The following is a description of a gene set: from publication Joseph J, Mudduluru G, Antony S, Vashistha S, Ajitkumar P, Somasundaram K (PMID 15318170) Histone deacetylase (HDAC) inhibitors induce growth arrest and apoptosis in a variety of human cancer cells. Sodium butyrate (NaB), a short chain fatty acid, is a HDAC inhibitor and is produced in the colonic lumen as a consequence of microbial degradation of dietary fibers. In order to dissect out the mechanism of NaB-induced growth inhibition of cancer cells, we carried out expression profiling of a human lung carcinoma cell line (H460) treated with NaB using a cDNA microarray. Of the total genes analysed, there were genes with a mean expression value of 2.0-fold and higher and genes with a mean expression value 3.0-fold and lower in NaB-treated cells. For a few selected genes, we demonstrate that their expression pattern by semiquantitative reverse transcription-polymerase chain reaction (RT-PCR) analysis is matching with the results obtained by microarray analysis. Closer view at the expression profile of NaB-treated cells revealed the downregulation of a total of genes associated with cytokine signaling, in particular, interferon gamma (IFNgamma) pathway. In good correlation, NaB-pretreated cells failed to induce interferon regulatory factor 1, an INFgamma target gene, efficiently upon IFNgamma addition. These results suggest that NaB inhibits proinflammatory cytokine signaling pathway, thus providing proof of mechanism for its anti-inflammatory activity. We also found that NaB induced three genes, which are known metastatic suppressors, and downregulated genes, which have been shown to promote metastasis. Upregulation of metastatic suppressor Kangai 1 (KAI1) by NaB in a time-dependent manner was confirmed by RT-PCR analysis. The differential regulation of metastasis-associated genes by NaB provides explanation for the anti-invasive properties of NaB. Therefore, our study presents new evidence for pathways regulated by NaB, thus providing evidence for the mechanism behind anti-inflammatory and antimetastatic activities of NaB. species: Homo sapiens Human Gene Set: JOSEPH_RESPONSE_TO_SODIUM_BUTYRATE_UP Genes up-regulated in H460 cells (non-small cell lung carcinoma, NSCLC) after treatment with sodium butyrate., and this is the list of marker genes: SAT1, PCMT1, PRKCB (protein kinase C beta), CLU, HADHB, NME2, ATP5MC3, RHOA, PSAP, S100P, IGF2, SEC61B, RAB11A, POLR2L, GSTP1, IFI30, SERPINB2, GPRC5A, ESYT2, FURIN, CETN2 (centrin 2), NR4A1, MT2A, SPOCK1, UQCRQ, GDI1, FABP4, TIMP1, CD82, COX6A1, PRDX1